Given this list of marker genes Ssh1, Tert, Fgf9, Pcsk5 (proprotein convertase subtilisin/kexin type 5), Pdgfb, Pak1, Mdm2, Iqgap1, Smo, Ddr2, Lrp1, Adamts1, Dock5, Nrp1, Fat1, Map3k7, Agt, Igfbp5, Atp7a, Xbp1, Dock7, Nr4a3, Dock4, Nox1, Myocd, Myo5a, here is a description of the gene set: Mouse Gene Set: GOBP_POSITIVE_REGULATION_OF_VASCULAR_ASSOCIATED_SMOOTH_MUSCLE_CELL_MIGRATION species: Mus musculus Any process that activates or increases the frequency, rate or extent of vascular associated smooth muscle cell migration.